The following is a description of a gene set: This event has been computationally inferred from an event that has been demonstrated in another species.<p>The inference is based on the homology mapping from PANTHER. Briefly, reactions for which all involved PhysicalEntities (in input, output and catalyst) have a mapped orthologue/paralogue (for complexes at least 75% of components must have a mapping) are inferred to the other species. electronically inferred by orthology from the curated human pathway studied in species Mus musculus part of: PTEN Regulation Reactome Pathway: Regulation of PTEN stability and activity, and this is the list of marker genes: Psmb5, Trim27, Psmc5, Psmb7, Psma3, Psmd6, Psmb4, Psmd13, Psma7, Rnf146 (NCBI Gene Id 68031), Psmd7, Ubb, Psma4, Csnk2b, Wwp2, Psma5, Psmd1, Psmd12, Psma2, Psmc6, Psmc1, Psmc2, Psmc3 (proteasome (prosome, macropain) 26S subunit, ATPase 3), Rps27a, Psma1, Otud3, Psmb6, Psmc4, Psma6, Tnks2